Given this list of marker genes AP3B2, AP3S1, AP3M2, AP3D1, AP3S2, here is a description of the gene set: studied in species Homo sapiens Human Gene Set: GOBP_SYNAPTIC_VESICLE_COATING The formation of clathrin coated pits in the presynaptic membrane endocytic zone, triggered by the presence of high concentrations of synaptic vesicle components. This process leads to, but does not include budding of the membrane to form new vesicles.